Given this list of marker genes NFAT5, FLII, TCF4, CDC37, NXPH3, SLC18A3, SUPT6H, EMSY, PLPPR2, NTF4, GRB2, KLF13, TRIM27, PER1, FNTA, LOXL4, CRY1, DMTF1, PIAS1, TIMELESS (NCBI Gene Id 8914), KLF2, GNA11, SENP1, ERO1B, CBLN1, KCNN2, CNPY4, SH3BP5, NRG2, FGF12, CACNA1D, S1PR5, UGP2, GNL1, RBM4B, CELF6, CADM2, RAB9A, RELA, SNX2, CTTNBP2NL, NUB1, CREB1, MAP3K11, KCNQ4, SOX12, OSBPL9, MAP4K2, ARHGAP36, ANP32A, ERC1, BAD, CSNK1D, PRR3, LDB1, WNT2B, EML3, SYT9, ZNF768, HSPB9, FAM217B, IGF2BP1, PHOX2A, PPP1R3D, SNAPIN, CDK5R1 (NCBI Gene Id 8851), KLHL7, KLF11 (NCBI Gene Id 8462), EPHA1, GGN, NFYC, MRPL49, C11orf68, LPCAT3, WWP1, NACC1, SLC46A1, UPF2, ASCL2, ARHGEF1, ELK1 (ETS transcription factor ELK1), ATP2A2, BCL6B, CACNA1A, ALS2, RBBP7, RAB2B, RCOR2, APLP2, ADCK1, MRPL2, ASIC1, C2CD2L, PTK7, TLCD4, DHH, HOXB7, BCL7C, PRMT1, TKFC (NCBI Gene Id 26007), CAMK2G, PIAS3, SWAP70, WHRN, L1CAM, MIR22HG, HTR7, CADM1, GPR3, TIPRL, MAP3K7, PDIK1L, TRMT1, GRIN2A, TRPC4AP, OAZ2, VAMP2, TAF11, ACER3, NDRG1, CHD6, ACE, AGBL5, EPB41, AJUBA, CDKL5, CGGBP1, STMN1, CHKA, WDR81, MIEF2, HYAL2, ROM1 (retinal outer segment membrane protein 1), SH3KBP1 (SH3 domain containing kinase binding protein 1), GPRASP1, KCNC3, CTR9, KAT2A, FBXL19-AS1, KANSL1L, HAP1, SLC35F5 (solute carrier family 35 member F5), NPAS4, PHF23, UBE2O (ubiquitin conjugating enzyme E2 O), SPATA6, EFCAB13, TAPT1-AS1, CPD (carboxypeptidase D), SPAST, MACROD2, KIF16B, CACNA1B, SLBP (NCBI Gene Id 7884), TMEM150A, FEV, PAK4, FBXO36, PEX14, HCN4, STARD13, SMARCD1, LHX3, BHLHE41, DCAF1, PCGF2, AHNAK, CCDC74B, TEAD2, PITPNA (phosphatidylinositol transfer protein alpha), WNT2, FUS, TAF6, CLDN11, AP3M2, HDAC6, LASP1, CORO1C, UTP18, TRIM28, TIMP3, SIPA1, MXD4, TAPT1, FOXP4, NLK, NCOA6, GK, DCUN1D4, CS, DDAH2, PTPN2, PMM1, ZNF282, FKBP8 (FKBP prolyl isomerase 8), MIR17HG, CDC25A, PPARGC1B, TMEM256 (transmembrane protein 256), KLC4, ONECUT1, SMARCE1, ARRDC1-AS1, PTBP3, HIPK1, KDM2A, LYRM1, COPS5, ING2, PSMC6, NEFM, CCDC74A, NXPH4, JADE2 (NCBI Gene Id 23338), KANK2, DRAP1, GAS7, CHAT (NCBI Gene Id 1103), HNRNPDL, CYP26B1, SMARCA5 (SWI/SNF related, matrix associated, actin dependent regulator of chromatin, subfamily a, member 5), FKBP14, RABEP2, PHF21A, HRH3 (NCBI Gene Id 11255), PLEKHB1, SH2D3C, HES7, BMPR2, SOX2, ME3, FIS1, PTCH2, ING3, MYLIP, ABHD1, RHOG, POU3F2, GLTP, SLC9A6, DDB1, BCL11B, TEF, PRKRA, NASP, RAP1GDS1 (Rap1 GTPase-GDP dissociation stimulator 1), KCNB1, GOLGA3, PLEKHA8 (NCBI Gene Id 84725), CCDC136, ANKS1A, TLX2, SMIM19, RTF1, PRICKLE3 (prickle planar cell polarity protein 3), SNX18, POU5F1, VKORC1L1, IQGAP1, here is a description of the gene set: Genes having at least one occurrence of the motif NNGGGGCGGGGNN in the regions spanning 4 kb centered on their transcription starting sites. This matches the SP1 transcription factor binding site V$SP1_Q4_01 (v7.4 TRANSFAC). Human Gene Set: SP1_Q4_01 species: Homo sapiens